The following is a description of a gene set: Human Gene Set: HP_HYPOPLASTIC_VERTEBRAL_BODIES studied in species Homo sapiens Hypoplastic vertebral bodies, and this is the list of marker genes: FUZ (fuzzy planar cell polarity protein), SUMF1 (NCBI Gene Id 285362), INPPL1 (inositol polyphosphate phosphatase like 1), LBR, GLB1, ACVR1, GNS, RINT1, SLC29A3, POLR3A, TCIRG1, TNFRSF11A (TNF receptor superfamily member 11a), PRKAR1A, CSPP1, KIAA0586, VANGL1, SLC35D1